The following is a description of a gene set: from publication Davicioni E, Finckenstein FG, Shahbazian V, Buckley JD, Triche TJ, Anderson MJ (PMID 16849537) Alveolar rhabdomyosarcomas (ARMS) are aggressive soft-tissue sarcomas affecting children and young adults. Most ARMS tumors express the PAX3-FKHR or PAX7-FKHR (PAX-FKHR) fusion genes resulting from the t(2;13) or t(1;13) chromosomal translocations, respectively. However, up to 25% of ARMS tumors are fusion negative, making it unclear whether ARMS represent a single disease or multiple clinical and biological entities with a common phenotype. To test to what extent PAX-FKHR determine class and behavior of ARMS, we used oligonucleotide microarray expression profiling on 139 primary rhabdomyosarcoma tumors and an in vitro model. We found that ARMS tumors expressing either PAX-FKHR gene share a common expression profile distinct from fusion-negative ARMS and from the other rhabdomyosarcoma variants. We also observed that PAX-FKHR expression above a minimum level is necessary for the detection of this expression profile. Using an ectopic PAX3-FKHR and PAX7-FKHR expression model, we identified an expression signature regulated by PAX-FKHR that is specific to PAX-FKHR-positive ARMS tumors. Data mining for functional annotations of signature genes suggested a role for PAX-FKHR in regulating ARMS proliferation and differentiation. Cox regression modeling identified a subset of genes within the PAX-FKHR expression signature that segregated ARMS patients into three risk groups with 5-year overall survival estimates of 7%, 48%, and 93%. These prognostic classes were independent of conventional clinical risk factors. Our results show that PAX-FKHR dictate a specific expression signature that helps define the molecular phenotype of PAX-FKHR-positive ARMS tumors and, because it is linked with disease outcome in ARMS patients, determine tumor behavior. Human Gene Set: DAVICIONI_RHABDOMYOSARCOMA_PAX_FOXO1_FUSION_UP species: Homo sapiens Genes up-regulated in RMS cells (rhabdomyosarcoma) expressing PAX3 or PAX7 fusions with FOXO1 compared to the fusion negative cell lines., and this is the list of marker genes: CD9, VWA5A, NRCAM, RWDD3, ALK, PELI1, ADAM10, DCX, GATM, ANK1, NTAN1, GADD45A, HDAC5, FGFR4, NR2F2, FAM3C, NEBL, GAREM1, PPP1R14B, CYRIA, MET, ITPKB, DIPK1A, OSTF1, NMRK1, SKP2, JUN, ACAT2, ASS1, FGGY, ANK2, BMP5, POU4F1, MEG3, ACKR3, CXCR4, TBC1D9, TNFAIP3, ARRB1, TMEFF1, MYCN, MORC4, VAV3, JAKMIP2, GPM6B, MMD, CARHSP1, STATH, NUP93, PDGFD, PRKAR2B, EYA1, ABAT, MYO18A, TMEM47, NELL1, TCF7L2, MYOD1, AQP3, ZNF395, EPB41L4B, MN1, TMX4, THEMIS2